Given this list of marker genes NDUFS7, NDUFS3, NDUFA8 (NADH:ubiquinone oxidoreductase subunit A8), MT-ND1, NDUFAF8, DMAC2, NDUFA7, NDUFS8, NDUFS5, NDUFB4, NDUFV3, DMAC1, FOXRED1, TMEM126B, NDUFAF6, NDUFA5, SFXN4, NDUFAF2, MT-ND4, NDUFAF5, OXA1L, COA1, MT-ND6, NDUFAF1, NDUFS6, NDUFA11, TMEM126A (transmembrane protein 126A), MT-ND2, TMEM186, MT-ND3 (NCBI Gene Id 4537), NDUFC1, NDUFB9, NDUFS4 (NCBI Gene Id 4724), NDUFB11, NDUFV2, NDUFAF7, ACAD9, NDUFB10, NUBPL, NDUFB7, HSPA9, NDUFB5, NDUFS2, NDUFB3, NDUFAF4, NDUFB2, NDUFA3, NDUFA1, NDUFV1, MT-ND5, NDUFA6, NDUFB8, NDUFAF3, NDUFS1, LYRM2, HSCB, NDUFA2, ECSIT, PYURF, NDUFA13, NDUFA12, NDUFAB1, NDUFA9 (NCBI Gene Id 4721), NDUFB1, NDUFC2, TIMMDC1, NDUFB6, NDUFA10, here is a description of the gene set: Complex I (NADH:ubiquinone oxidoreductase or NADH dehydrogenase) utilises NADH formed from glycolysis and the TCA cycle to pump protons out of the mitochondrial matrix. It is the largest enzyme complex in the electron transport chain, containing 11 core and 34 accessory subunits. Seven subunits (ND1-6, ND4L) are encoded by mitochondrial DNA, the remainder are encoded in the nucleus. The enzyme has a FMN prosthetic group and 8 Iron-Sulfur (Fe-S) clusters. The subunits are assembled together in a coordinated manner via preassembled subcomplexes to form the mature holoenzyme. At least 24 so-called "assembly factor" proteins, acting intrinsically or transiently, are required for constructing complex I although their exact roles in the biogenesis are not fully understood. Reactome Pathway: Complex I biogenesis part of: Respiratory electron transport studied in species Homo sapiens